Given this list of marker genes SLC25A4, TPM2, DPM2, KLHL41, SLC52A2, WWOX, PPP2R2B, LAMP2, SLC6A3, MTM1, AIFM1, SLC18A3, ACTA1, HTT, TPM3, KLHL40, LGI3, MUSK, TSPOAP1, MYOD1, MPZ, DOK7, TUBA1A, DDC, GPHN, TWNK, SNCA, CLTC, GFM1, ALG11, NEB, POLG2, PET117, RRM2B, GBA1, LMOD3, MAGEL2, TH, GLRA1, FRRS1L, POLG, MRPS16, LAMA2, PDE8B, SLC2A3, PRKN, CFL2, ATP13A2, NUP88, RAPSN, SLC39A14, ATP7B, PAM16, KIF21A, PRNP, here is a description of the gene set: Human Gene Set: HP_HYPOKINESIA species: Homo sapiens Hypokinesia Abnormally diminished motor activity. In contrast to paralysis, hypokinesia is not characterized by a lack of motor strength, but rather by a poverty of movement. The typical habitual movements (e.g., folding the arms, crossing the legs) are reduced in frequency.